Given this list of marker genes LY6G6F-LY6G6D, EXOC3L4, ITGB3, TUBB1, MMRN1, ACTN1, EFHC2, LTBP1, F2RL3, XYLT2, DNAAF3, ALOX12, CRISP3, CBFA2T3, CFAP45, HBD, LINC02284, CXCL2, GCSAML, PTGS1, IRAG1, LINC02470, SEPTIN5, ITPRID2-DT, LINC02770, TLN1, C1orf116, RSU1 (Ras suppressor protein 1), PADI4, TUBA8, BEND2, TREML1, CAPN1-AS1, KCNMB1, AQP10, ITGB1BP2, CXCL3, HGD, RBPMS2, LGALSL, CNST, SELP, GOT2P7, C19orf33, LAT, PLEK, MPIG6B, NRGN, COL24A1, MCEMP1, ITGA2B, WFDC1, ARHGAP6, PIRAT1, CMTM2, LINC02701, XIRP2 (NCBI Gene Id 440924), PPBP, GP6 (NCBI Gene Id 51206), MPL, MDM1, FCER1A, H4C8, RPL17P22, LINC00534, SERPINB1, MYOM1, P2RX1, LINC00504 (long intergenic non-protein coding RNA 504), ADCY6, HYAL3, ENSG00000258422, PKHD1L1, PCP2, RAB27B, TUBAL3, PTCRA, CAPN11, INAFM2, THBS1, ZYX, CHRNA2, FERMT3, TMEM91, LEFTY1, SLC8A3, PDLIM1, RUFY1, CLEC1B, SEC14L5, CMTM6, SLC37A1, CPA3, EGF (NCBI Gene Id 1950), EFCAB13-DT, RGS18, LY6G6F, GRM3-AS1, LIMS1, PGAM1P8, LINC00989, CCDC175, HPSE, PF4, GP5, ELOVL7, GP1BA, LINC02915 (long intergenic non-protein coding RNA 2915), ANKRD33B, ENSG00000258803, ENSG00000233968, PROSER2, ENSG00000241525, ACRBP, GP9, here is a description of the gene set: from publication Cao J, O'Day DR, Pliner HA, Kingsley PD, Deng M, Daza RM, Zager MA, Aldinger KA, Blecher-Gonen R, Zhang F, Spielmann M, Palis J, Doherty D, Steemers FJ, Glass IA, Trapnell C, Shendure J (PMID 33184181) The gene expression program underlying the specification of human cell types is of fundamental interest. The study authors generated human cell atlases of gene expression and chromatin accessibility in fetal tissues. For gene expression, the study authors applied three-level combinatorial indexing to >110 samples representing 15 organs, ultimately profiling ~4 million single cells. The study authors leveraged the literature and other atlases to identify and annotate hundreds of cell types and subtypes, both within and across tissues. Our analyses focused on organ-specific specializations of broadly distributed cell types (such as blood, endothelial, and epithelial), sites of fetal erythropoiesis (which notably included the adrenal gland), and integration with mouse developmental atlases (such as conserved specification of blood cells). These data represent a rich resource for the exploration of in vivo human gene expression in diverse tissues and cell types. Marker genes curated from the annotated cluster as represented in the Descartes Human Gene Expression During Development database. Human Gene Set: DESCARTES_FETAL_ADRENAL_MEGAKARYOCYTES species: Homo sapiens